Given this list of marker genes FABP2, CTNNB1, ERC2, RIMS1, CTBP1, INSC, DCTN1, CTNNA2 (NCBI Gene Id 1496), RIMS3, SPTBN5, GPSM2, PHLDB2, PKD2, CLASP1, GUCY1B1 (NCBI Gene Id 2983), SAPCD2, NUMA1, PCLO, PPFIA3, PRKCZ, MYO5B, TCHP, OSBPL2, CLASP2, STXBP1, BSN, PHLDB1, RIMS2, ERC1, here is a description of the gene set: The complete extent of cell cortex that underlies some some region of the plasma membrane. studied in species Homo sapiens Human Gene Set: GOCC_CELL_CORTEX_REGION